Given this list of marker genes BTBD3, PLEKHB1, ATP5MC2, TOX3, KARS1, CST7, TRBC2, VCL, POLD3, CTCF, SEPTIN6, RAP2A (RAP2A, member of RAS oncogene family), SKP2, RNF126, GPX2 (NCBI Gene Id 2877), SYT1, EIF4B, BRD7, ATMIN, VGLL4, AARS1, GALNT7, MPHOSPH6, WDR59, MCM3, AMIGO2, BICC1, DAZAP2, NAXD, TESC, HNRNPF, SLC38A2 (solute carrier family 38 member 2), VPS4A, FZD10, RGL1, CUL4A, GCHFR, EPRS1, XRCC5, VPS26A, TMED2, BTF3, COPZ1, CEP15 (centrosomal protein 15), NDUFS5, ZMYND11, TOR3A, DHODH, NARF, COG4, TERF2IP, TERF2, ADK, BAG1, GLG1, MET, CAT (NCBI Gene Id 847), LTA4H, QPRT, SNTB2, AK6, MAGEB2, CARS1, PSMD7, TUBB (tubulin beta class I), CSNK2A2, SPRY2, AQP3, PEG10, DDX50, TFF3, PLLP, DROSHA, BTG1, TPM2, ATP6V0D1, AKR1C3, TSR1, SF3B3, MARCKSL1, CNN3, FOXA2, PPA1, ACD, TRBC1, POLR2M, GDF15, ZWINT, PRSS3P2, ELP5, CDKN2A, MACROH2A2, HNRNPA1, PDF, MRPS27, JUN, CTSC, VARS1, COLGALT2, POGLUT2, MME, GABARAPL2, TCF12, MCCC2, MRPL23, CDKAL1, GSE1, CADPS2, LMCD1, CENPN, NIP7, TNS3, FGGY, AKR1B1, EFNB2, LCK, OXCT1, AKR1C1, H4C3, CBFB, CEMIP2, SAR1A, NNT, LAMP1, EPHB2, WNK1, CD24, TM4SF1, TARS1, GOT2, TXNL4B, TIMM23, LRIG1, VSNL1, ZBED1, CAVIN3, CRIPTO, THAP11, DDX19A, TMEM208, TRAF5, KIZ, PRIM1, SAT1, SGCE, CDK1, ADA, ITPA, CARD10, PRKX, PLPP3, CES2, DDX19B, IPO5, HBE1, GCSH, NAE1, RBM47, PRCP, MFNG, PRR13, ANAPC5 (NCBI Gene Id 51433), BORA, MAGED1, HOXC6, CLEC11A, HUS1, POLR2A, IST1, DNAJC9, PLAC8, PCCA, DAB2, LSM7, WWOX, WASHC2C, HLTF, PLIN2, MTF2, CHGB, CYTL1, TXNIP, SERPINF1, TOMM70, FYN, HNRNPA3, SLC25A14, TCF3, SLC35D1, CDKN2C, LCP1, PROM1, FXYD6 (FXYD domain containing ion transport regulator 6), EZH2, AZGP1, PDIA4, MYB, MON1B, LARP4B, CIAO2B, CMC2, EDC4, KDM4C, here is a description of the gene set: Genes up-regulated in polysomal and total RNA samples from SW480 cells (primary colorectal carcinoma, CRC) compared to the SW620 cells (lymph node metastasis from the same individual). Human Gene Set: PROVENZANI_METASTASIS_UP Tumour onset and progression are due to the accumulation of genomic lesions, which alter gene expression and ultimately proteome activities. These lesions are thought to affect primarily the transcriptional control of gene expression. In the present study, we aimed at evaluating the genome-wide occurrence of alterations in the translational control exploiting an isogenic, phenotypically validated cellular model of colorectal cancer (CRC) transition from invasive carcinoma to metastasis. In this model, microarray profiling shows that changes in the level of messenger ribonucleic acid (mRNA) association with polysomes occur more than 2-fold than changes in the level of total cellular mRNA. When common to both the total and polysomal compartments, these changes are also homodirectional, being amplified in magnitude at the polysomal level. Comparison between the transcriptional and the translational fluctuations revealed distinct signatures of statistically over-represented gene functions, involving the program of cell proliferation for both levels of analysis, while the apoptosis and the translation programs were affected mainly at translation. Looking for an upstream determinant of translational deregulation, we found an increase in the hyperphosphorylated form of the 4E-BP1 protein in the metastatic cell line, possibly resulting in an increased activation of cap-dependent translation due to increased activity of the eIF4E protein. Analysis of the distribution profiles for the 5' untranslated region (5'-UTR) length of the changed genes showed an association between longer 5'-UTRs and the probability for the relevant gene to be altered translationally, consistent with enhanced eIF4E function. This genome-wide analysis is in favour of a model of profound alteration of translational control in late CRC progression. It also suggests polysomal mRNA profiles as a new, informative dimension for the study of transcriptome imbalance in cancer. species: Homo sapiens from publication Provenzani A, Fronza R, Loreni F, Pascale A, Amadio M, Quattrone A (PMID 16531451)